The following is a description of a gene set: Genes having at least one occurrence of the highly conserved motif M38 TGACCTTG in the regions spanning 4 kb centered on their transcription starting sites. This matches the SF1 transcription factor binding site V$SF1_Q6 (v7.4 TRANSFAC). from publication Xie X, Lu J, Kulbokas EJ, Golub TR, Mootha V, Lindblad-Toh K, Lander ES, Kellis M (PMID 15735639) studied in species Homo sapiens Human Gene Set: TGACCTTG_SF1_Q6 Comprehensive identification of all functional elements encoded in the human genome is a fundamental need in biomedical research. Here, we present a comparative analysis of the human, mouse, rat and dog genomes to create a systematic catalogue of common regulatory motifs in promoters and 3' untranslated regions (3' UTRs). The promoter analysis yields 174 candidate motifs, including most previously known transcription-factor binding sites and 105 new motifs. The 3'-UTR analysis yields 106 motifs likely to be involved in post-transcriptional regulation. Nearly one-half are associated with microRNAs (miRNAs), leading to the discovery of many new miRNA genes and their likely target genes. Our results suggest that previous estimates of the number of human miRNA genes were low, and that miRNAs regulate at least 20% of human genes. The overall results provide a systematic view of gene regulation in the human, which will be refined as additional mammalian genomes become available., and this is the list of marker genes: FZD9, CKMT1B, CCNE1, EEF1A2 (NCBI Gene Id 6669), EPN3, HCN4, ZNF768, KCNMB2, TNNI1, DEXI, GK, AFG3L2, ATP6V1B1, ATP6V0C (ATPase H+ transporting V0 subunit c), NDFIP1 (NCBI Gene Id 80762), MGST3, RPH3A, GABRA3 (NCBI Gene Id 2556), WWP1, NNAT, MTX2, LINC01567, CHD2, ATP5F1B, UBL3, CDH16, CATSPER2, APP, RPRD2, ELAVL3, GPR52, PHF5A, ZRANB1, ADCY1, TMEM161B, KIRREL3, BEND6, TUBB4A, RAB3A (NCBI Gene Id 96387), CHCHD10, XYLT1, NTF3, CX3CL1, ALDOA, ARFGAP2, PHACTR3, SLC38A3, ACO2, C6orf47, UCHL1, KIAA0586, UBA1, TRMT2A, MYL3, RAB11FIP5, RGS7, RBMX, TFRC, RAPGEF5, LINC00472, RNF19B, ANKRD28, FGF9, KIN, YWHAH, EPS8L2 (NCBI Gene Id 64787), ARF3, RANBP10, RNF139, LRFN5, RS1, ATP1B1, LINC01089, JADE2, SLC30A3, CLC, WDFY3-AS2, LCA5, RNF4, CHGA, ST8SIA5, ABTB2, TBL1XR1, AK2, SLC37A2, CCDC92, FBH1, SIK3, ST3GAL5, SYNGR1, HOXC13, UQCR10, HSPA9, NTNG2 (NCBI Gene Id 84628), SDHD, CNTN2, COMTD1, CHAT, ST3GAL1, HIGD1A, TBX6, WBP1L, PNOC, SDK1, HCN1, MNT, ATP5MC3, PRPSAP1, VSNL1, SIK2 (salt inducible kinase 2), CAMK2G, UQCRC1, ASTN2, MSI2, PCDH7, FSTL3, SNTG1, OR10A5, KIF5A, MAP1B, IQSEC1, SEMA3F, COX4I1, RHCG, EMC3, SYT17, ZDHHC21, RBMS1, SV2A, WDFY3, AUH, SNPH, COX5B, NAA25, MEF2D, GABPA, TOMM40, NTMT1, STK32A, ATP5PF, WDR72, CYC1, MYOM3, DNAJC11, NRXN2, VAMP2, CACNB2, AMY2A, LUC7L3, RHOT1, NIPSNAP2, CKB, TBC1D15, HSPD1, MTCH2, MEF2C (myocyte enhancer factor 2C), PANK1, NDUFB5, SH3GL2 (NCBI Gene Id 6456), GPR55, HSPE1, RIN2, MASP1, NALF2, ESRRA, RILP, ZNF644, MADD, KLHL36, TIMM9, VDAC2, GDPD1, FANCD2, LAMB2, PPP1R16B, CTSD, STAC2, HMGB3, ADAMTSL5, CNTF, RCAN2, NXPH4, RANBP1, CASQ2, KIRREL3-AS3, NCDN, PDHX, GPBP1L1, ATP5F1C, TRAP1, PPP3CC, SLC6A8, ENSG00000291228 (NCBI Gene Id 652276), CA2, IDH3A, PDIA3, MRPL47, VASP, NRSN2, SEMA7A (semaphorin 7A (JohnMiltonHagen blood group)), FBXL22, MAL, HNF1B, TPPP3, DHRS11, NPTX2, MIDEAS, FNDC5, DIRAS1, KCNG4, SPMIP6, CEL, CDK16, SCN5A, YY1AP1, HHATL, SLC2A4 (solute carrier family 2 member 4), SLITRK1, KCNK1, TMEM35A, WWC1, SRCIN1, CTDSPL2, OGDHL, KLK15 (kallikrein related peptidase 15), CS, EMC8, DNER, IMMT, POLR3D, DIPK1B, MTRES1, GABARAPL1, SLC9A7, BLCAP, FBXW4, TAB3, ABHD3, INSR, ZBTB43, FAM81A, AMPD3, CNTLN, ATP6AP2, NYAP1, RREB1, TLCD5, CDKL5, HOXC10, TIMM8B, MAEA, MED26, ATP5MC1